Given this list of marker genes THBD, TOP2B, CALD1, ITGA6, SEMA3C, ITGA2, DDX21, RRM2, PLEC, PTP4A1, NAP1L1, SF3A2, NBN, TACC1 (transforming acidic coiled-coil containing protein 1), LAMA3, DUSP7, EMP1 (NCBI Gene Id 2012), THBS1, FN1, CCND1, MYC, EGFR, CDH3, IGF1R, ROCK1 (Rho associated coiled-coil containing protein kinase 1), RDX, AHNAK, JAK1, PRKAR1A, ID1, EREG, here is a description of the gene set: species: Homo sapiens Solar ultraviolet B (UVB) acts as both an initiator and promoter in models of multistage skin carcinogenesis. We found that, whereas UVB induces apoptosis in human papillomavirus-16 E6/7-immortalized keratinocytes, it inhibits markers of differentiation in human foreskin keratinocytes (HFK). Potential mechanisms for this differential response were examined by DNA microarray, which revealed that UVB alters the expression of three of the four human inhibitor of differentiation/DNA binding (Id) proteins that comprise a class of helix-loop-helix family of transcription factors involved in proliferation, differentiation, apoptosis, and carcinogenesis. These results were verified by RT-PCR and immunoblot analysis of control and UVB-irradiated primary and immortalized keratinocytes. Whereas Id1 was downregulated in both cell types, Id2 expression was upregulated in primary HFK, but not immortalized cells. In contrast, Id3 expression was significantly increased only in immortalized cells. The differential expression pattern of Id2 in response to UVB was recapitulated in reporter constructs containing the 5' regulatory regions of this gene. Id2 promoter activity increased in response to UVB in HFK, but not in immortalized cells. To identify the regulatory elements in the Id2 promoter that mediate transcriptional activation by UVB in HFK, promoter deletion/mutation analysis was performed. Deletion analysis revealed that transactivation involves a 166 bp region immediately upstream to the Id2 transcriptional start site and is independent of c-Myc. The consensus E twenty-six (ETS) binding site at -120 appears to mediate UVB transcriptional activation of Id2 because point mutations at this site completely abrogated this response. Chromatin immunoprecipitation and electrophoretic mobility-shift assays verified that the Id2 promoter interacts with known Id2 promoter (ETS) binding factors Erg1/2 and Fli1, but not with c-Myc; and this interaction is enhanced after UVB exposure. Similar to the effects of UVB exposure, ectopic expression of Id2 protein in primary HFK resulted in inhibition of differentiation, as shown by decreased levels of the terminal differentiation marker keratin K1 and inhibition of involucrin crosslinking. Reduction of Id2 expression by small interfering RNAs attenuated the UVB-induced inhibition of differentiation in these cells. These results suggest that UVB-induced inhibition of differentiation of primary HFK is at least, in part, due to the upregulation of Id2, and that upregulation of Id2 by UVB might predispose keratinocytes to carcinogenesis by preventing their normal differentiation program. from publication Simbulan-Rosenthal CM, Trabosh V, Velarde A, Chou FP, Daher A, Tenzin F, Tokino T, Rosenthal DS (PMID 16007217) Genes down-regulated in response to UVB radiation in HFK cells (keratinocytes) immortalized by overexpression of HPV E6 and E7 viral oncogenes. Human Gene Set: SIMBULAN_UV_RESPONSE_IMMORTALIZED_DN